The following is a description of a gene set: Human Gene Set: HP_ABNORMAL_CIRCULATING_METABOLITE_CONCENTRATION studied in species Homo sapiens Abnormal circulating metabolite concentration An abnormal level of an analyte measured in the blood., and this is the list of marker genes: ETFA, NFKB2, PNPLA8, GATM, WDR73, SLC26A1, NDUFS7, MMUT, BCS1L, ITGB2, STX1A, ALDH5A1, USB1, RBP4, HNF1B, DHCR7, SQOR, PDHX, NCF4, GATA1, MPO, NDUFC2, LACC1, HFE, CLDN19, HNF1A, CASR, ABCB11, IL36RN, TRMU, KLRC4, HSD17B4, SUCLG1, ROBO1, ERCC8, INPPL1, ATP5F1D, HLCS (NCBI Gene Id 3141), WDR4, FOXP1, MET, SLC6A3, TAMM41, CPA1, MPZ, BLK, PDX1 (pancreatic and duodenal homeobox 1), RHAG, WDPCP, UFD1, AASS, BBS5, LHX4, NOTCH3, ATP1A1, PAX2, DHCR24, CLCNKB, NKX2-1, CAVIN1, ZNRF3, RNU7-1, TLR3, LMAN1, SCO1, LARGE1, ACAT2, PWAR1, MAD2L2, SDCCAG8, SLC25A4, LMNB2, IL10 (NCBI Gene Id 3586), B4GAT1, APOA5, SDHA, COL12A1, PKD1, BAZ1B, PCYT1A, ALG12 (NCBI Gene Id 79087), ABCC8 (ATP binding cassette subfamily C member 8), KLHL41, POLE, COMT, BRCA2, SEC24C, EPHX2, AIFM1, DAG1, STX16, RFXANK, TMEM260, CEL, CALM1, SLCO1B3, AKR1D1, HADH, FAM111B, ABCD1, SLC2A3, GATC, KRT18, HAMP, APOA1, UGT1A1, KCNJ2, IFNGR1, PGM2L1, CYP11A1, CHD7, ENO3, SLCO2A1, CTNS, RILPL1, LAMP2, NUP205, DEAF1, COG2, SLC19A1 (solute carrier family 19 member 1), SEMA4D, MKRN3, JMJD1C, MEN1, CPOX, DIO1, MT-TL1, TMEM165, SCN5A (sodium voltage-gated channel alpha subunit 5), NEB, TRHR, ETHE1, ALDH7A1, SLC6A6, NDUFB8, ATAD1, SLC34A2, SLC6A19, HNRNPDL, MGME1, COX6A2, NPHS1, MRPS7, PHKA2, CFHR1, MYT1L, PHKA1, TSFM, PRTN3, NSD1, SDHD, LMNA, TMEM126B, OTC, PKHD1, PCCB, PIGY, ZBTB20, CDKN2B (NCBI Gene Id 1030), PLA2G4A, ABHD5, AR, RNASEH1, NFE2L2, COL3A1, VCP, SETX, MTMR14, TTPA (NCBI Gene Id 7274), KY (NCBI Gene Id 339855), ACSF3, TBX5, POLRMT, AP5Z1, PNKP (polynucleotide kinase 3'-phosphatase), AFP, BOLA3, IFNG, LRP6, FRG1, SMAD4, AVPR2, CLPX, BCAP31, MST1, TOP3A, POMGNT1, HJV, COX6B1, TPM2, TPO, GABRA3, DGCR2, INF2, FTL, SLC12A6, YARS1, KLKB1, SGCD, SMARCAL1, MT-ND4 (mitochondrially encoded NADH:ubiquinone oxidoreductase core subunit 4), SQSTM1, PKLR (NCBI Gene Id 5313), IQSEC2, IARS1, GCDH, CFHR3, TK2, KCNJ10 (potassium inwardly rectifying channel subfamily J member 10), APOC3, AFG2A, PLCE1, CFI, SUGCT (succinyl-CoA:glutarate-CoA transferase), PFKM, ACAD8, ACTA1, SLC6A18, KRT5, ALPL, SLC30A9, AMPD1, PSTPIP1, UQCRFS1, IVD, ANLN, CD244, MMP1, CCT5, COL4A1, ALG14, GLRX5, PTPN22, ALDH18A1, TBL2, PPARG, KCNA1, RRAGC, DNAJB11, TXNRD2, RXYLT1, QRICH1, BBS9, TTC8, C1QBP, MT-TF, GLS, BICC1, RRM2B, SH2B1 (SH2B adaptor protein 1), NUP214, NDUFS4, IL12A-AS1, NSUN2, PEX7, CIITA, ADRA2A, TBX1, HR, POMC, SKIC3, PPM1B, NOTCH2NLC, KCNE2 (NCBI Gene Id 9992), PTPN6, NDUFAF6, EPAS1, HLA-DQB1, GTF2I, MYH14, TKT, ARL6, CPS1, PNLIP, NNT, TRPM6 (transient receptor potential cation channel subfamily M member 6), COX10, EFL1, CRB2, BSCL2, SLC9A3, SLC2A2, KIF1B, KCNJ18, CC2D2A, GBE1, PNPLA6, BBS4, RAI1, PEX14, HPD, FILIP1, RNF168, ETFB, MPDU1 (NCBI Gene Id 9526), RNU4ATAC, TMPRSS15, MECP2, CIDEC, SLC30A10, ITGB4, ADCY10, ATP5MK, SCO2, FECH, PAX8, OTUD5, PLAU, BMPR1A, MAGED2, XIAP, GALM, SDHAF2, PKD2, NAB2 (NGFI-A binding protein 2), DPM3, SLC16A1 (solute carrier family 16 member 1), GFER, RTL1, PGM1, PABPN1, NDUFS6, TIMM22, TRIP13, TRPS1, CEP19, TTN, NEUROD1, ODC1, NDUFS2, CYP19A1, C3, NDUFAF4, FXYD2, KNG1, EBP, GNAS, SYK, WDR35, ACADM, ZPR1, OTX2, LYRM7, ABCC2, COL6A1 (NCBI Gene Id 1291), DBH, TANGO2, MLXIPL, DNAJC19, DLD, GNPTAB, EIF4H, NRAS, DNM2, ATP6V1E1, GLDC, THBD, COQ2, CYP24A1, NLRC4, STAR, CTLA4, CNNM2, TFR2, GLYCTK, LIMS2, BCL6, ENPP1, STAT2, BLVRA, NPHS2, DUOXA2, METTL27, ETFDH, BAG3, FAM20C, KCNJ5, PIGH, NSMCE2, COQ7, DNMT3B, POLG, NT5C3A, CASK, ALG6, TBK1, HAVCR2, EPG5, LTBP4, HLA-DPB1, CDKN2C, TUFM, ACOX2, TIAM1, LONP1, MYZAP, CTNNB1, AEBP1, ATP5F1E, FAN1, NOS1, KRT14, ARNT2, MT-TV, RAF1, PEX26, UCP2, NUP133, NKX2-5, FGFR1 (fibroblast growth factor receptor 1), SGCB, GAMT, PRPS1, UBE3B, GNAS-AS1, GALNT3, GSR, RAG2, SCNN1A, NEFH, LYST, PTH1R, MT-ND2, MPV17 (NCBI Gene Id 4358), GPR35, COL25A1, MTR, LDLRAP1, KDM1A, RINT1, IL37, GPIHBP1, PBX1, SLC39A8 (NCBI Gene Id 64116), TCAP, FLI1 (NCBI Gene Id 2313), ATP6V0A2, OTULIN, LAMC2, GCM2, CRELD1, STEAP3, TKFC, ERAP1, PIGT, GNE, TNNT2, SCN4B, NUP85, H19, BBS2, TG, MAX, GALK1, BCL10, SCNN1B (NCBI Gene Id 6338), SYNE1, APP, HADHA, NUP37, BCKDHA, MED12, HACD1, INS, MSMO1, SOX5, MC2R, LRPPRC, LBR, IFT56, PCBD1, FGF23, CDKN2A, ALG8, NARS2, GPHN, MAT1A, PIK3C2A, TMTC3, C1QB, PLA2G6, OCRL, PHYH, NPR2, KCNJ11, FOXRED1, ALDOB, RPIA, CARD10, MIF, MC4R, PEX19, STIM1, MT-CO1, SGPL1, PIGN, NDUFA6, INPP5K, LPL, LZTFL1, LDLR, TICAM1, FOXI1, NDUFS3, CRPPA, UBA1, AMPD3, WNK4, NBAS, KCNE3 (potassium voltage-gated channel subfamily E regulatory subunit 3), CLCN5, B2M, SPTB, NSDHL, FKBP14, MYPN, PIK3R5, COA7 (cytochrome c oxidase assembly factor 7), PCK1, FLAD1, LIPT2, FOXN1, NLRP12, CALM3, TRDN, HERC2, SUCLA2, PREPL, INVS, SLC51B, PYROXD1, ADK (NCBI Gene Id 132), KLHL9, FN1, SERPINA1, RAG1, CYP27A1, CEP290, IL23R, POMGNT2, UROS, CBLIF, SEC61A1, EHHADH, GGPS1, TERT, C4A, CD46, PEX11B, MIEF2, UROD, SORD, B3GALNT2, COX16, CD320, MDH1, KL, MRPL39, SERPINF1, DAAM2, COX20 (NCBI Gene Id 116228), CA12, NOS1AP, CSF1R, NR3C2, ABCB6, UROC1, GTF2IRD2, CALM2, BBS10, CNBP, DGCR8, FGFR3, TCN2, NAGS, VPS33B, IGF1, TP53, TRAF3 (TNF receptor associated factor 3), PLCG1, QRSL1, LIPA, HMOX1, TDP2, PRKCSH, PLIN4, DSG2, CFTR, PSPH, DGUOK, SLC6A20, XK, TMEM127, IFT27, TRNT1, TDP1, BCKDHB, LAMB3, UNC93B1, FBXL4, CHCHD10, KCNJ1, TRIM28, GOSR2, CREB3L3, SCN10A, SVIL, MYO1E, ATPAF2, NR0B1, HMGCS2, ASPA, JAG1, PROP1, CASQ1, MOCOS, NHERF1, ALG11, GYG1, TRIP4, VAPB, MAGI2 (NCBI Gene Id 9863), CP, CACNA1D, SPTA1, HADHB, CELA2A, PDK3 (NCBI Gene Id 5165), GATA3, KCNH2, PLVAP, LIPE, LMF1, SLC30A2, MAP2K1, XDH (NCBI Gene Id 7498), SCYL2, LMO1, PTPRO, TMEM70, MT-CO3, THRB, ACAD9, HSD11B2, BAAT, NDUFA11, TNFRSF1A, CFH, CAV1, SNTA1, ABCA1, SLC31A1, DNAJC30, JAG2, ALG9, MCEE, UBAC2 (NCBI Gene Id 94902), LIG3, NF1 (neurofibromin 1), CUL3, HINT1, RFX7, SC5D, TNPO3, NDUFAF5, DNAJB6, MMACHC, ALG5, PCSK9, CSF2RB, SPR, IFT140, APTX, COQ4, HRAS, VPS13A, MYC, PANK2, AP2S1, SYNE2, TMEM67, CYP11B1, VRK1, MT-ATP8, MYH7, COG8, SARS2, RAB27A, GP1BB, CLDN16, CYP17A1, MYO5B, PLG, YME1L1, FARSA, RYR1, MMAA, KYNU, ALMS1, ANKH, PWRN1, NUP107, CCND1, CYP11B2, PEX6, SLC22A4 (solute carrier family 22 member 4), AGPAT2, TIMMDC1, COL6A2, MCFD2 (multiple coagulation factor deficiency 2, ER cargo receptor complex subunit), POLD1, GANAB, ASL, ARMC5, WRN, GPC3, GNA11, PNPO, DSG1, RACGAP1, SNORD115-1, RFC2, BCKDK, SLC10A1, CPT1A, SLC2A9, IRF4 (NCBI Gene Id 4592), ANXA11, GLUD1, LTC4S, IYD, REN, MOCS1, SCNN1G, RHD, PDGFRB, MT-ATP6, ANO5, ARG1, BBS7, GAPVD1, WDR19, ORAI1, ARPC5, MTHFR, STAB1, IRF6, DPYS, KARS1, MVK, GUCY2D, IL12RB1, APOB, IMPDH2, HCFC1, NDUFAF3, ASAH1, ITK, CARD9, SKIC2 (SKI2 subunit of superkiller complex), ADA2, NPPA, HSD3B2, SPEG, MTTP, SLC7A7, TNFSF15, ALDOA, CHKB, ITGA3, DNAJB4 (DnaJ heat shock protein family (Hsp40) member B4), MKS1, FHL1, PEX10, KLHL3, TRIO, SCP2, SLC26A4, MYMK, HEXB, ANKFY1, FOCAD, PSMB9, BSND, C19orf12, ERCC4, CCN6, MUC1, HACE1, PNPLA2, CCDC134, MT-TE, SLC51A, ALAD, FOXE1, CARS2 (NCBI Gene Id 79587), MKKS (MKKS centrosomal shuttling protein), FLNC, COG4, APPL1, DGKE, HLA-DRB1, DPAGT1, DYRK1B, PMM2 (NCBI Gene Id 5373), GNMT, SLC37A4, POU6F2, TRPC6, FLT1, PEX1, MRAP, PDSS2, C2orf69, NDUFS8 (NCBI Gene Id 4728), GPR101, PC, NLRP3, BTK, PHGDH, GHR, SEMA7A, SLC25A38, TDO2, MUTYH, CSF2RA (NCBI Gene Id 8282), APC2, ATM, GFPT1, FAS, DOLK, LMOD3, GALT, MMAB, DCXR, LEPR, GPD1, C1GALT1C1, NDUFAF1, ATAD3A, PEX2, PTH, CLCNKA, ABCD4, SERPINA6, LMBRD1, SLC4A4, LYN, PEX13, DUX4L1 (double homeobox 4 like 1 (pseudogene)), G6PD, MYL2, PLA2G7, CBS, STAT4, RBCK1, MT-TL2, ABCC6, GBA1, APOE, IFT74, SLCO1B1, MLX, IRF5, DUOX2, FTCD, GALE, ARHGDIA, CAPN3, AP1S3, STAT6, EPB42, P4HA2, TRIM32, TCEAL1 (NCBI Gene Id 96422), TRAPPC2L, GOLGA2, LARS2, HNF4A, SLC22A5, XRCC4, AMT, NDUFB11, GYS2, PAPPA2, FOXP3, DMD, DNA2, IL6, ALDH4A1, ALDH6A1, DCLRE1C, MT-ND3, SLC34A3, PET100, SPTBN1, PIEZO1, CAPNS1, TWNK, APOL1 (apolipoprotein L1), SEMA4A, ISCU, HIRA, BIN1, CHD8, LIPC, MT-TI, SLC33A1, EXTL3, GNPAT, ANK2, TRMT10C, CTH, HBB, RFXAP, LHX3, FKBP6, SERAC1, KLF1, MT-ND1, HLA-DPA1, TBCK, STX11, TNFRSF11A, ATP6V0A4, EMP2, SETD2, MYL1, PTEN, SLC52A1, EARS2, HSD3B7, MICOS13, BBIP1, CCDC78, MRPS2, HMGCL, LDB3, PEX16, ALG2, NDUFV2, KBTBD13, VPS37D, POU1F1, SLC40A1, AIRE, SLC41A1, GOT2, GLIS3, ZNFX1, SNX10, PET117, GCH1, PCCA, STOX1, DYSF, SUOX, NDUFB9, MIR140, EPB41, ATP7B (ATPase copper transporting beta), SAR1B, GK, GIPC1, GEMIN4, STING1, KLF11, PYGL, MB, OBSCN, HS6ST2, VMA21, MTRR, USP8, NCF1, GNPTG, SLC25A26, ATP5F1A (NCBI Gene Id 502), NGLY1, MT-ND6, SLC4A2, NDUFAF8, SPIB, PDHB, BMP6, LIMK1, VARS2, MSTO1, DNAJC21, SCLT1, TFAM, UQCRC2, COQ8B, GPX1, CMPK2, SLC35A2, SDHC, VIPAS39, IL6R, NLRP1 (NLR family pyrin domain containing 1), IFT172, QDPR, REPS1, CLIP2, POU2AF1, RMRP, CDC73, CYC1, SLC12A3, NFU1, KIF23, BCAT2, CAD, RHCE, CAV3, PEX5, HNRNPA1, ATP8B1 (NCBI Gene Id 5205), LAMA3, PLXNA1, ACAT1, IBA57, IDH2, FDFT1, CYP2R1, SLC11A2, NR1H4, SLC12A1, CFB, INSR, SLC6A8, COX8A, PHKG1, CDKN1B, RREB1, LRP12, BUD23, MEFV, RASA1, CD2AP, ABCB7, SNORD116-1, KCNN4, IFIH1, MTO1, MRPS14, UBR1, DES (desmin), SECISBP2, MYO5A, FAT4, BTD, DIS3L2, TSHR, TMEM43, ATP7A, ELP1, PITRM1, SLC17A5, COL7A1, ARHGAP24, NEFL, SLC39A14, UBE2A, MT-TP, TRPV6, ACADVL, DPM2, HESX1, EMD, MAGEL2, LAMB2, BMP2, PSAP, WNK1, TARS2, CLCN7, SLC5A1, ESS2, PEX12, PAH, SCN4A, HAL, SLC29A3, POMK, NUP160, NDUFV1, DLK1, LRP5, TEFM, PGAM2, TNNT1, PAX4, TMPRSS6, PHKG2, SIL1, TMEM38B, NR4A2, DZIP1L, NUBPL, TCF4, SLC25A42, BBS12, DPM1, TFG, LEP, TMEM199, MT-TN (mitochondrially encoded tRNA-Asn (AAU/C)), APOA2, ATP5F1B, MICU1, UQCRH, MCM10 (NCBI Gene Id 55388), ASS1, CCR1, CRYAB, IL6ST, BCL2, HMGCR, NOS3, LAMA2 (laminin subunit alpha 2), ADAMTS3, EIF2AK3, MATR3, CAMKMT, PTS, FDX2, CYP27B1, SPINK1, ASNS, OAT, LPIN1, MPC1, UPB1, PRKCD, MEG3, APRT, IGFALS, DEF6, MIPEP, POMP, ALB, CCDC47, PRKAR1A, CFL2, CDAN1, FOS, MCCC2, CDKN1C, TTR, GTF2IRD1, MT-ND5, HNRNPA2B1, CD55 (CD55 molecule (Cromer blood group)), MLIP, FLII (FLII actin remodeling protein), TBCD, ARVCF, APOC2, VDR, RFX5, CORIN, CLDN10, RRM1, ACADS, SERPINE1, NUP93, FKTN, DOK7 (docking protein 7), THPO, CNOT1, STX5, PLEKHM1 (NCBI Gene Id 9842), SLC4A1, TPM3, FH, ERCC6, PRSS2, SH2D1A (NCBI Gene Id 4068), NDUFB3, SLC20A2, ABCD3, ITGA7, CACNA1S, SGCG, GATB, PRSS1, POMT1, PSMB8, AQP2, NPHP1, MARS1, HLA-B, G6PC1, STK11, DCDC2, SEC63, OSGEP, UNC13D (NCBI Gene Id 201294), TBL1X, RET, MCCC1, MRPS22, TSHB, PLIN1, SLC26A3, IL12B, IL12A, ALG1, MFN2, FAH, PPOX, PLEC, DHX16 (DEAH-box helicase 16), FKRP, SLC39A4, DTYMK, PDP1, TIA1, AGXT, MRM2, SLC25A36, NAA10, EGF, FBP1, NDUFB10, SLC22A12, ELF4, IL1RN, OPA1, UMOD, ERGIC1, TAFAZZIN, COL9A3, ANGPTL3, NDUFS1, TOR1AIP1 (NCBI Gene Id 84764), LAMA1, TJP2, GCSH, AMACR, SPTBN4 (NCBI Gene Id 80322), AIP, BVES, TBC1D8B, KMT2D, RNF31, ALK, UNC45A, MPI, MMADHC, NDUFA13, TYMP, PDHA1, ATP6V1A, TALDO1, ABCB4, RRAGD, POR, SLC2A1, PPP1R17, SLC36A2, SLC34A1, DNM1L, RPS20, NFS1, LIPT1, ZEB2, SLC3A1, PHOX2B, NPAP1, REST, ADSS1, AP1S1, LIN28B, MRPL3, ABCG5, ISCA1, AP1B1, DGCR6, TREX1, PEX3, ADCY3, TMEM270, ALAS2, HSPG2, MMEL1, PUS1, HPRT1 (hypoxanthine phosphoribosyltransferase 1), HLA-DQA1, OSTM1, GMPPB, CDKN1A, NT5E, CA2, SBDS, FARSB, SPTAN1, SAMD9, ZMPSTE24, PIEZO2, PSAT1, B4GALT1, PLEKHG5, BBS1, TCIRG1, TBCE, FTH1, GLUL, CA5A, ATIC, NADK2, SLC25A11, SGCA, MTX2, PIGA, KIT, CNTN1, KIF12, ARPC1B, CDH23, BICD2, CTRC, WT1, KCNQ1, NDUFAF2, ACSL5, GNB2 (G protein subunit beta 2), COX5A, POLG2, SMPD1, CCBE1, PYGM, CACNA1C, COG6, MTHFD1, POPDC3, BAG5, NDUFA2, ITPR3, MYCN, NDUFA1, SLC25A20, DCAF17, COG7, IFT122, MYF6, SMCHD1, ADAMTS13, CFAP418, L2HGDH, HK1, SLC5A5, ELN, TNFRSF9, SLC35C1 (NCBI Gene Id 55343), AKT2, COPA, HMBS, PDGFB, PPM1K, KCNE1, MOCS2, DUX4, RSPO1, MEGF10, HSD17B10, AKAP9, FAM111A, SCARB2, PHKB, ABCA2, PLAAT3, MEF2A, TRPV4, GLA, NFKBIL1, ANK1, PHEX, MT-TW, PRUNE1, POLR3A, PIK3CG, TRAPPC11, ABCG8, SYNJ1, LDHA, SARDH, TLR4, COQ9, VHL, POGLUT1, KRAS, HHAT, TBX19, IRF8, DMGDH, PNP, PSMB10, VPS50, DNMT3A, DMP1, CETP, ZFX, CLCN2, BRAF, CHEK2, GYPC (glycophorin C (Gerbich blood group)), PAFAH1B1, COL6A3, PGK1, VAC14, BTNL2, TAT, PRF1, HTT, ZNF699, CYP7A1, DLST, CRLF1, GCK, TNFRSF11B, GALNT2, PRODH, CCDC115, SNUPN, GRHPR, BCO1 (beta-carotene oxygenase 1), MYOT, DGAT1, CYP7B1, ACTN4, TNFSF11, GAA, PRDX1, SDHB, CYP3A4, POMT2, ATP6AP1, FLCN, VPS33A, NR3C1, AGL, AHCY, PSMB4, ACTN2, COL4A3, RTN2, SLC25A15, STXBP2, RFX6, FBN1, SLC25A13, SCAPER, MDH2, USP53, LCAT, CPT2, NHLRC2, MT-TK, TF